The following is a description of a gene set: species: Mus musculus Mouse Gene Set: GOBP_CELLULAR_RESPONSE_TO_PH Any process that results in a change in state or activity of a cell (in terms of movement, secretion, enzyme production, gene expression, etc.) as a result of a pH stimulus. pH is a measure of the acidity or basicity of an aqueous solution., and this is the list of marker genes: Scnn1b, Kcnk9, Rab11fip5, Scnn1a, Kcnk1, Hyal1, Gh, Pkd1l3, Kcne1, Slc9a1, Gja1, Gpld1, Kcnk3, Rab11b, Asic1, Chp1, Scnn1g, Trpv1, Kcnk4, Pkd2l1, Gpr68, Mcoln1, Kcnk18, Insrr, Gna11, Hvcn1, Asic2